Given this list of marker genes NPAS4, TNRC6B, AGO4, AGO3, TNRC6C, TNRC6A, AGO1, MOV10, AGO2, here is a description of the gene set: Regulation of NPAS4 mRNA translation Human Gene Set: REACTOME_REGULATION_OF_NPAS4_MRNA_TRANSLATION studied in species Homo sapiens